Given this list of marker genes ERBB2, EGFR, AREG, HBEGF, EGF, TGFA, BTC, EREG, here is a description of the gene set: studied in species Homo sapiens The series of molecular signals initiated by binding of a ligand to an epidermal growth factor receptor (EGFR/ERBB1) on the surface of a cell, followed by transmission of the signal by a heterodimeric complex of ERBB2 and EGFR. ERBB2, which does not bind any known ligand, is activated through formation of a heterodimer with another ligand-activated ERBB family member such as EGFR. Human Gene Set: GOBP_ERBB2_EGFR_SIGNALING_PATHWAY